Given this list of marker genes C1qbp, Nlrc3, Cmklr1, Jak3, Nfkb1, Lilra5, Irak3, Tigit, Thbs1, Tlr2, Arrb2, Tlr8, Pibf1, Nod2 (NCBI Gene Id 338538), Il10, Mefv, Ccr7, Slamf1, Acp5, here is a description of the gene set: Any process that stops, prevents, or reduces the frequency, rate, or extent of interleukin-12 production. Mouse Gene Set: GOBP_NEGATIVE_REGULATION_OF_INTERLEUKIN_12_PRODUCTION studied in species Mus musculus